The following is a description of a gene set: Any process that modulates the frequency, rate or extent of lysosome organization. species: Homo sapiens Human Gene Set: GOBP_REGULATION_OF_LYSOSOME_ORGANIZATION, and this is the list of marker genes: PPP3CB, TMEM106B, SCARB2, FLCN, MCOLN1, IRGM, BECN1, GRN, TREX1, TFEB, MTOR, LAPTM4B, FNIP1